Given this list of marker genes CCNC (cyclin C), FBXW7, TLE1, UBB, HDAC9, MAML2, EP300, TBL1X, UBC, RBX1, SNW1, HDAC7, MAMLD1, MYC, TBL1XR1, SKP1, HDAC6, MAML3, HEY2, CREBBP, CDK8, NBEA, HDAC4, NOTCH1, HIF1A, HEYL, HDAC3, HES1, TLE4, TLE2, RPS27A, MAML1, TLE3, KAT2B, NCOR1, HDAC5, HDAC10, HES5, RBPJ, CUL1, HEY1, KAT2A, UBA52, HDAC8, HDAC2, HDAC11, NCOR2, HDAC1, here is a description of the gene set: studied in species Homo sapiens Human Gene Set: REACTOME_NOTCH1_INTRACELLULAR_DOMAIN_REGULATES_TRANSCRIPTION NOTCH1 Intracellular Domain Regulates Transcription